Given this list of marker genes Gtf2h2, Gm47014, Ptcd2, Gm35215, Gm35279, BC001981, 4932411K12Rik, Nsa2, Naip1, Ankrd31, Rpl27a-ps4, Tmem171, Gm4815, Tnpo1, Fcho2, Btf3, Gm8847, H2bl1, Gm23955, Arhgef28, Utp15, Gm41043, Gm19010 (predicted gene, 19010), Polk, Gm26559, Gm22661, 1700099I09Rik, Gm29543, Shld3, Srek1ip1, Gfm2, Naip3-ps1 (NCBI Gene Id 53898), Gm41030, Gm21976, Gm9465, Gm36638 (predicted gene, 36638), 2310005E17Rik, Gm24032, Gm33447, Pik3r1, Map1b, F2r, F2rl1, Nt5el, Shisal2b, Gm48745, Taf9, Gm6114, Gm19108, Ccnb1, Gm9828, Gm807, Naip5, Cdk7, Gm16335, Btf3l4b, Tbca, Srek1, Smn1, Hmgb1-ps9, Ppwd1, 6430562O15Rik, Hexb, Aggf1, Cenpk, Rps18-ps6, Hmgcr, Gm6211, Gm2534, 5330431K02Rik, Gm24261, Gm17190, Bdp1, Ankra2, Sgtb, Iqgap2, Dph3b-ps, Gm10739, Naip3, Enc1, Naip6, Gm18413, S100z, Rps18-ps4, Marveld2, Mrps36, Zbed3, Gm18134, 2310020H05Rik, Gm48049, Gcnt4, Ccdc125, 1700029F12Rik, 2610204G07Rik, Ak6, Gm48350 (NCBI Gene Id 115488190), Gm41041, C430039J16Rik, Gm8712 (predicted gene 8712), Gm5454, Zfp366, F2rl2, Gm41031, Prp2rt, Sec61bl, Gm16416, Snora47, Ankdd1b, Pde8b, Gm18601, Fam169a, Tmem174, Gm29927, Gm47052, Mast4, Rpl31-ps13, Gm48212, D130062J10Rik, Nln, Gm34388, Gm24471 (predicted gene, 24471), Cd180, Or1j23-ps1, Crhbp, Rnf180, Gm17832, Gm2379, Gm8756, Slc30a5, Gm32880, Sv2c, Gm25631, Trappc13, Mccc2, Poc5, Wdr41 (NCBI Gene Id 218460), Foxd1, Cert1, Erbin, 5930438M14Rik, Mrps27, Otp, Trim23, Gm10257, Gm7054, Serf1, Gm4938, Rad17, Gm2445, Gm30551, Rgs7bp, Adamts6, Naip2, Htr1a, Cwc27, 1700012J22Rik, A930014D07Rik, Lncenc1, Cenph, Gm46436, Cartpt, Ocln, here is a description of the gene set: species: Mus musculus Mouse Gene Set: chr13D1